Given this list of marker genes Ddx3y (NCBI Gene Id 77494), Igll1, Ina, Lrrn1, Zic2, Chia1, Cnr2, Crp, Vps13c, Pcnp, Sdf2, Klk1b9, Xrcc5, Ccr3, Chl1, Sbp, Six4, Glrp1, Htr4, Eif2s3y, Mstn, Fmo5, Clcn1, Slc1a5, Sult2a2, Igkv1-135, here is a description of the gene set: from publication Maekawa T, Shinagawa T, Sano Y, Sakuma T, Nomura S, Nagasaki K, Miki Y, Saito-Ohara F, Inazawa J, Kohno T, Yokota J, Ishii S (PMID 17189429) Genes down-regulated in MEF cells (embryonic fibroblast) upon knockout of ATF2. Transcription factor ATF-2 is a nuclear target of stress-activated protein kinases, such as p38, which are activated by various extracellular stresses, including UV light. Here, we show that ATF-2 plays a critical role in hypoxia- and high-cell-density-induced apoptosis and the development of mammary tumors. Compared to wild-type cells, Atf-2(-/-) mouse embryonic fibroblasts (MEFs) were more resistant to hypoxia- and anisomycin-induced apoptosis but remained equally susceptible to other stresses, including UV. Atf-2(-/-) and Atf-2(+/-) MEFs could not express a group of genes, such as Gadd45alpha, whose overexpression can induce apoptosis, in response to hypoxia. Atf-2(-/-) MEFs also had a higher saturation density than wild-type cells and expressed lower levels of Maspin, the breast cancer tumor suppressor, which is also known to enhance cellular sensitivity to apoptotic stimuli. Atf-2(-/-) MEFs underwent a lower degree of apoptosis at high cell density than wild-type cells. Atf-2(+/-) mice were highly prone to mammary tumors that expressed reduced levels of Gadd45alpha and Maspin. The ATF-2 mRNA levels in human breast cancers were lower than those in normal breast tissue. Thus, ATF-2 acts as a tumor susceptibility gene of mammary tumors, at least partly, by activating a group of target genes, including Maspin and Gadd45alpha. studied in species Mus musculus Mouse Gene Set: MAEKAWA_ATF2_TARGETS